Given this list of marker genes PHLDA1, AURKA (NCBI Gene Id 8465), here is a description of the gene set: species: Homo sapiens PHLDA1 (TDAG51), the product of a gene involved in breast cancer progression, interacts with aurora kinase A (AURKA). While unphosphorylated PHLDA1 promotes AURKA ubiquitination and degradation, AURKA-mediated phosphorylation of PHLDA1 results in down-regulation of PHLDA1 protein levels. Ectopic expression of PHLDA1 strongly antagonizes AURKA-triggered oncogenic phenotypes, suggesting PHLDA1 downregulation as one of the key mechanisms by which AURKA promotes breast cancer. part of: G2/M Transition Reactome Pathway: Interaction between PHLDA1 and AURKA